Given this list of marker genes RNU6-1135P, RAB30-DT, PRSS23-AS1, MTNR1B, RBMXP3, OR7E2P, RPL32P24, ANKRD33BP7, TUBAP2, SNRPGP16 (NCBI Gene Id 106480270), SETP17, RNU6-311P, LDHAL6DP, RSF1-IT2, CKS1BP4, ANKRD42-DT, PICALM (NCBI Gene Id 8301), ANKRD33BP8, KCTD21-AS1, LINC02748, MTND6P25, TYR, COPS8P3, LINC02728, CLNS1A, H3P34, CHORDC1, OSBPL9P3, PAK1, ENSG00000254787, LINC02711, GAPDHP70, ENSG00000254675, COX6A1P4, MIR708, FNTAP1, RAB30, CCDC81, MTCYBP41, ENSG00000309946, EEF1A1P49, CCDC83, RN7SL225P, RAB38, LINC02695, LINC02951, INTS4, NARS2, CREBZF, ENSG00000288018, CCDC89, TRIM64DP, ME3, TRIM49, ARL6IP1P3, BCAS2P1, TMEM126A, COX5BP4, TUBB4BP4 (TUBB4B pseudogene 4), CBX3P7 (NCBI Gene Id 100421975), MIR4300HG, DLG2-AS2 (NCBI Gene Id 124900639), TENM4, MIR6755, HNRNPA1P72, MIR5579, RNU6-560P, HNRNPCP8, FZD4-DT, FAT3, ALG8, DLG2, PSMA2P1, RPL7AP57, RPL21P95, PTP4A1P6, PRCP, THRSP (thyroid hormone responsive), TRIM64, TRIM64B, GRM5-AS1, GAB2, RNU6-544P, DISC1FP1, RNU6-16P, RSF1-IT1, ANKRD42, EIF2S2P6 (NCBI Gene Id 100129629), OSBPL9P2, RSF1, RNU7-59P, MTND4LP18, ANKRD33BP9, ANKRD33BP10, LINC02746, C1DP5, MIR4490, MIR3166, ENSG00000255084, TRIM53AP (tripartite motif containing 53A, pseudogene), KCTD21, EED, MIR1261, NOX4, TRIM51BP, TRIM49D2, LINC02734 (NCBI Gene Id 105369413), TMEM135, RPS28P7, ZNF75CP, CCDC90B-AS1, ENSG00000207299, LINC02756, FAM181B, KCTD14, RNU6-1292P, HIKESHI, FZD4, AQP11, GRM5, PRSS23, PGAM1P9, RPL7AP54, NDUFB11P1, UBTFL1, OR7E13P, TRIM49D1, NDUFC2-KCTD14, XIAPP2, PCF11-AS1, TRIM77, FOLH1B, SNORA70E, TRIM51EP, RPS3AP42, NDUFC2, TRIM49C, UBTFL2, CTSC, TMEM126B, USP35, AAMDC, PCF11, NAALAD2, DDIAS, UBTFL10 (UBTF like 10 (pseudogene)), LINC02720, CCDC90B, CYCSP28, MTND1P35, MIR4300, TRIM64EP, RNU6-126P, HNRNPCP6, SYTL2, SLC25A1P1, FTH1P16, TRIM53BP (tripartite motif containing 53B, pseudogene), MOB4P2, here is a description of the gene set: Human Gene Set: chr11q14 species: Homo sapiens